Given this list of marker genes HS3ST1, SLAMF8, GAPLINC, RGL1, SLFN13, PDK4, DEFA1, C1QA, RASSF4, CXCL5, STAB1 (NCBI Gene Id 23166), PTGER3, TMEM45B, CD24, OLIG1, SGTB, MMP9, PLPP3 (phospholipid phosphatase 3), C1QB, RPS6KA2, SELENOP, CHIT1, PCSK5, FJX1, MSC-AS1, RGCC, AOC1, ADGRE3, CD9, SLPI, MMP8, PADI2, ADTRP, SERPINF1 (serpin family F member 1), ACP5, MAPK13, ID3, CD24P4, ADGRG3, CTSB (NCBI Gene Id 3896), SLC7A8, OLFML2B, CEACAM6, CCL4, MMP1, SGK1, OTOA, PADI4, NPL, F13A1, CST7, PPBP, IL7R, KLF2, CXCL2 (NCBI Gene Id 2920, C-X-C motif chemokine ligand 2), RGL4, ABHD12, PPP1R1B, NRP2, CD59, APOE, DOCK4, LGMN, HNRNPC, MMP12, GGTA1, FCHO2, HRH4, DAB2, TREM2, FPR3, FRMD4A, TEX15, GPNMB, TACSTD2, DPY19L1P1, CD1B, DEFA4, CCL13, NRP1 (neuropilin 1), FABP3, CD24P2, CCL7, LGALS12, FOLR3, MEIKIN, ST14, TRAV22, FUCA1, BPI, DACH1, CCL3, MS4A2 (membrane spanning 4-domains A2), RNASE1, CEBPE, ABCB5, TMTC1, CXCL3, ACE, CORO2A, RAB42, SLC38A6, CHI3L1, CLEC5A, PID1, ME1, EMP1, HS3ST2, MREG, IL1R1, BLNK, PYROXD2, TGFBI, TLR7, RIT1, GLUL, RTN1, PPP2R2B, CTSLP8, FCER1A, S100P, C1QC, PATJ, GSDME, A2M, SRPX, LGALSL, KCNJ15, PLA2G7, S100B, SLC16A10, RARRES1, LHFPL2, ATP6V0D2 (NCBI Gene Id 245972), SLCO2B1, CCL23, IL1R2, VSTM1 (NCBI Gene Id 284415), TCN1, TSPAN2, RAPH1, CXCL1, MAOA, RASGRP1, CCL18 (C-C motif chemokine ligand 18), C5AR1, CEACAM8, ANXA3, MAGI2-AS3, MAF, here is a description of the gene set: Human Gene Set: TAKEDA_TARGETS_OF_NUP98_HOXA9_FUSION_10D_DN from publication Takeda A, Goolsby C, Yaseen NR (PMID 16818636) Genes down-regulated in CD34+ hematopoetic cells by expression of NUP98-HOXA9 fusion off a retroviral vector at 10 days after transduction. NUP98-HOXA9, the chimeric protein resulting from the t(7;11)(p15;p15) chromosomal translocation, is a prototype of several NUP98 fusions that occur in myelodysplastic syndromes and acute myeloid leukemia. We examined its effect on differentiation, proliferation, and gene expression in primary human CD34+ hematopoietic cells. Colony-forming cell (CFC) assays in semisolid medium combined with morphologic examination and flow cytometric immunophenotyping revealed that NUP98-HOXA9 increased the numbers of erythroid precursors and impaired both myeloid and erythroid differentiation. In continuous liquid culture, cells transduced with NUP98-HOXA9 exhibited a biphasic growth curve with initial growth inhibition followed by enhanced long-term proliferation, suggesting an increase in the numbers of primitive self-renewing cells. This was confirmed by a dramatic increase in the numbers of long-term culture-initiating cells, the most primitive hematopoietic cells detectable in vitro. To understand the molecular mechanisms underlying the effects of NUP98-HOXA9 on hematopoietic cell proliferation and differentiation, oligonucleotide microarray analysis was done at several time points over 16 days, starting at 6 hours posttransduction. The early growth suppression was preceded by up-regulation of IFNbeta1 and accompanied by marked up-regulation of IFN-induced genes, peaking at 3 days posttransduction. In contrast, oncogenes such as homeobox transcription factors, FLT3, KIT, and WT1 peaked at 8 days or beyond, coinciding with increased proliferation. In addition, several putative tumor suppressors and genes associated with hematopoietic differentiation were repressed at later time points. These findings provide a comprehensive picture of the changes in proliferation, differentiation, and global gene expression that underlie the leukemic transformation of human hematopoietic cells by NUP98-HOXA9. species: Homo sapiens